Given this list of marker genes SH2B1, GFM2, TRIM8, IQSEC2, ACOX1, EXTL3, here is a description of the gene set: Lack of intentional participation in interactions with another person. Human Gene Set: HP_NO_SOCIAL_INTERACTION No social interaction studied in species Homo sapiens